The following is a description of a gene set: A ribonuclease P complex that generally contains a single RNA molecule and several protein molecules. Examples of this complex are found in Archaeal species. Mouse Gene Set: GOCC_MULTIMERIC_RIBONUCLEASE_P_COMPLEX studied in species Mus musculus, and this is the list of marker genes: Pop7, Rpp14, Rpp38, Rpp21, Rpp25, Rpp30, Rpp40, Pop1, Pop4, Pop5